Given this list of marker genes Tnfrsf14, Dusp3, Lmo1, Tnfrsf13c, Ndfip1, Btnl2, Ctnnb1 (catenin beta 1), Abl2, Btla, Zbtb1, Dlg1, Shh, H2-Ea, Ppp3ca, Pla2g2f (phospholipase A2, group IIF), Itch, Cblb, Gli3, Dpp4, Efnb1, Ankle1, Lgals9, Ccl19, Icos, Abl1, Lilrb4a, Tfrc, Clec2i, Slc7a1, Ager, Selenok, Sart1, Nr5a2, Kat5, Zfp35, Sox13, Fanca, Cd1d2, Ido1, Anxa1, Rag1, Scgb1a1, Rps3, Ambra1, Il18, Kitl, Cd3e, Rhoh, Stat5a, Cgas, H2-Ab1, Cd55b, Pnp, Ccl21a, Zbtb7b, Cbfb, Nck2, Il1a, Vnn1, Tbx21, Trex1, Ceacam1, Il7, H2-Eb2, Laptm5, Kcnk18, Ptpn2 (protein tyrosine phosphatase, non-receptor type 2), Ildr2, Il4, Nlrp3, Ephb6, Pdcd1, Cd209d, Slamf1, Cd160, Ascl2, Slc4a1, Adrm1, Blm, Cd44, Socs6, Wnt10b, H2-Oa, Duxbl1, Nckap1l, Il4i1, Ada, Pbrm1, Ccdc88b, Zmiz1, Erbb2, Tnfrsf9, Brd4, Adora2a, Spta1, Lrrc32, Adk, Cyp26b1, Peli1, Zc3h12d, H2-M3, Prkcz, Rasal3, Ripk2, Sash3, Il15, Kat2a, Aif1, Vav1, Pde5a, Il1rl2, Cdkn2a (cyclin dependent kinase inhibitor 2A), Ctsg, Cebpb, Brd2, Efnb2, Slc4a2, Tgfb1, Egr3, Ccl2, Runx1, Mir301, Jak3, Epo, Vsir, Nfkbiz, Lgals8, Sdc4, Smad7, Cd59a, Sh2b3, Tspan32, Carmil2, Cd86, Bcl6, Igf1, Ifng, Foxp3, Arg2, Icosl, Socs1, Cd40lg, Skint1, Zfp609, Vsig4, Ccr6, Zc3h8, Pawr, Cd55, Malt1, Dock8 (NCBI Gene Id 76088), Sftpd, Hsph1, Mdk (NCBI Gene Id 17242), Zeb1, Smarca4, Ptprc, Ccr7, Rorc, Tgfbr2 (NCBI Gene Id 76304), Prdx2, Tnfsf14, Rhoa, Ccr2, Hmgb1, Ccl20, Lag3 (NCBI Gene Id 16768), Actl6a, Cd80, Foxn1, Tmem131l, Ptpn6, Crtam, Cd83, Csk, Tox, Loxl3, Ep300, Ctla2a, Bad, Rara, Pag1, Zp3, Hspb1, Gpnmb, Il12a, Pik3r6, Ap3d1, Thy1, Bcl10, Card11, Glmn, Pf4, Rc3h1, Ufl1, Foxj1, Klhl22, Tigit, Dicer1, Lilrb4b, Il20rb, Zfp608, Vtcn1, Mad1l1, Ccl5, Actb, Cd27, Il4ra, Casp3, Il6st, Tnfsf18, Scrib, Prdm1, Slfn1, Ihh, Bid, Cd69, Cd1d1, Hsp90aa1, Drosha, Il21, Hes1, Tnfsf4 (NCBI Gene Id 226545), Phf10, Hlx, Klhl25, Cd74, Lgals1, H2-Aa, Pycard, Il7r, Gpam, Arid1a, Cav1, Pla2g5, Il12b, Itgal, Rag2, Il12rb1, Cd209c, Ripor2, Havcr2, H2-DMa, Igf2 (NCBI Gene Id 16002), Tespa1, Rc3h2, Fgl1, Efnb3, Smarcc1, H2-DMb2, Prelid1, Fadd, Gnrh1, Jak2, Dusp10, Cyld, Arg1, Prkcq, Ctla4, Coro1a, Cd59b, Il36b, Il1b (NCBI Gene Id 16176), Il2ra, Dtx1, Il2, Hspd1 (NCBI Gene Id 15510), Ap3b1, Lef1, Clec4g, Tcf7, Sos2, Fancd2, Cd47, Pten (phosphatase and tensin homolog), Sh3rf1, B2m, Mapk8ip1, Pla2g2a, Opa1, Fas, Cd274, Fcho1, Tarm1, Cd209a, Tnfrsf21 (tumor necrosis factor receptor superfamily, member 21), Smarce1, Tnfsf13b, Fbxo38, Ifnb1, Shb, Zfp683, Cd37, Il3, Prkaa1, Fgl2, Smarcc2, Bmp4, Dusp22, Arid2, Nck1, Btn2a2, Smarcd3, Rasgrp1, Slc46a2, H2-Ob, Cyrib, Brd7, H2-T23, Tyk2, Gimap5, Itpkb, Sos1, Lgals3, Ripk3, Cd81, Mettl3, Prkar1a, Stat5b, Tnfsf11, Marchf7, Lat, Rac2, Pck1, Zap70, Cd300a, Traf6, Dnaja3, Smarcd1, Adam8, Cd209e, Il6, Sirpa, Twsg1, Gata3, Flot2, Cd276, Zc3h12a, Xcl1, Nrarp, Gimap3, Lep, Sox12, Clptm1, Pdcd1lg2, Lck, Sox4, Znhit1, Socs5, Cd28, Sit1, Cd4, Nkap, Xbp1, Dlg5, Foxo3, Cd6, Spn, Il2rg, Igfbp2, Irgm1, Nfkbid, H2-Eb1, Ptpn22, Bmi1, Hfe, Cd46, Irf1, Prnp (prion protein), Cd24a, Mir326, Tnfaip8l2, Syk, Ephb4, Smarcb1, Ywhag, Smarcd2, Pla2g2d, Cd244a, Tnfsf9, Lax1, Tsc2, Tnfrsf1b, Runx3, H2-DMb1, Braf, Il27, Il23a, Dhps, Vcam1, Actl6b, Cd5, Dapl1, Smarca2, here is a description of the gene set: Mouse Gene Set: GOBP_REGULATION_OF_T_CELL_ACTIVATION Any process that modulates the frequency, rate or extent of T cell activation. studied in species Mus musculus